Given this list of marker genes LRP1, CALHM2, KCNJ8, IL13, LDLR, CX3CR1, CX3CL1, SNCA, TREM2, SPHK1, C1QA (NCBI Gene Id 712), ITGAM, CLU, AGER, TLR1, CST7, TAFA3, GRN, TLR9, TLR6, ZEB2, CCL3, JUN (NCBI Gene Id 3725), JAK2, MAPT, LRRK2, NAGLU, NR1D1, STAP1, MIR181B1, PTPRC, MMP8, C5AR1, SYT11, CNTF (NCBI Gene Id 1270), CTSC, AZU1, MIR181C, IFNG, IL1B, TNF, IL33, PSEN1, FPR2, IFNGR1, ADORA2A, APP, AIF1, TYROBP, TTBK1, IL6 (interleukin 6), MIR142, TLR3, ITGB2, SMO, MIR128-1, IFNGR2, here is a description of the gene set: species: Homo sapiens A change in morphology and behavior of a glial cell resulting from exposure to a cytokine, chemokine, cellular ligand, or soluble factor. Human Gene Set: GOBP_GLIAL_CELL_ACTIVATION